Given this list of marker genes PEX1, PEX26, NRAS, PEX2, SOS2, LRPPRC, CBL, PSAT1, RRAS (RAS related), RIT1, RASA2, PEX10, ENPP1 (NCBI Gene Id 5167), SLC35A2, TRIP11, COG8, RNU4ATAC, CHMP2B, DOCK11, PEX12, PEX3, ALG9, PEX14, MAPT, HNRNPK, TBC1D24, PSEN1, SLC26A2, PEX5, MRAS, VCP, SOS1, PTPN11, ITPR1, FOXF1, ABCC6, LAMA5, PEX16, TRAF7, PEX11B, GRN, ATP6V1B2, LZTR1, SQSTM1, SLC31A1, SPRED2, PEX6, HRAS, RRAS2, RNU4-2, PIGA, PIGN, KRAS, TMEM106B, PEX19, RAF1, PEX13, EFNB1, EBP, TREM2, here is a description of the gene set: Thickened nuchal skin fold species: Homo sapiens A thickening of the skin thickness in the posterior aspect of the fetal neck. A nuchal fold (NF) measurement is obtained in a transverse section of the fetal head at the level of the cavum septum pellucidum and thalami, angled posteriorly to include the cerebellum. The measurement is taken from the outer edge of the occiput bone to the outer skin limit directly in the midline. An NF measurement greater than 5 mm at 14 to 17+6 weeks of gestation, or 6 mm at 18 to 28 weeks has been associated with a markedly increased risk for Down syndrome. Human Gene Set: HP_THICKENED_NUCHAL_SKIN_FOLD